The following is a description of a gene set: from publication Chen Y, Wang X (PMID 31504780) species: Mus musculus Genes predicted to be targets of miRBase v22 microRNA mmu_miR_499_3p in miRDB v6.0 with MirTarget v4 prediction scores > 80 (high confidence targets). Mouse Gene Set: MIR_499_3P, and this is the list of marker genes: Fgf12, Mcfd2, Prpf40a, Zfp280c, Pcnx4, Rab1a, Cert1, Gpm6a, Sfpq, Parp12, Sfrp1 (secreted frizzled-related protein 1), Zfp706, Zxdb, Galnt1, Fn1, Stx17, Recql, Otud6b, Paqr5, Adal, Fam120c, Ctcf, Man2a1, Naalad2, Fgf7, Mrgprx2, Zfp319, Prg4, Apobec4, Spock3, Stambpl1, Zfp384, Yy1, Usp6nl, Fam91a1, Cntn4, Rasgef1a, Npr3, Zdhhc16, Srd5a3, Pcp4, Ptpn3, Cpeb4, Lyz3, Dlx2, Pde1c, Pdgfra, Myh15 (myosin, heavy chain 15), Ogfrl1, Gabra5, 1810010H24Rik, Trappc3, Sp4, Slc2a13, Neu1, Kpna1, Ube2k, Armcx2 (armadillo repeat containing, X-linked 2), Zdbf2, Uba2, Klhl13, Orc5, Pcdh7, Sanbr, Wdr82, Plekhm2, Zic2, Fgd1, Zfhx4, Ascl1, Nufip2, Senp7, Ddx3x, Pan3 (NCBI Gene Id 72587), Rnf214, Raph1, Dnajb4, Lox, Clk4, Mctp1, Zic3, Ptprk, Oscar, Atad2b, Pde3b, Ncoa2, Ccr1, Rufy3, Zfhx3, Tcf7l2, Rps6kb1, Lamp2, Tmem229a, Ctso, Arhgap36, Pxdn, Map3k12, Slc25a33, Spty2d1, Tsga8, Ash1l, Bnip2, Bmper, Dnmt3a, Itpk1 (NCBI Gene Id 217837), Gcc2, Trim36, Gucy1a1, Myt1l, Bmi1, Gpatch8, Fgd6 (FYVE, RhoGEF and PH domain containing 6), Ccl2, Hk2, Rbm46, Scai, Crebrf, Foxo1, Nus1, Spin4, Phf1, Sf3b1, Phip, Tent4b, Cyria, Ccdc15, Tmeff2, Peg10, Tbce, Palld, Acod1, Cyfip2, Ube3a, Fam120a, Tmcc3, Ankrd39, Ppp6c, Rbm12b2, Zfp558, Actr3b, Lypla1, Olfm3, Surf2 (surfeit gene 2)